Given this list of marker genes Trpv4, Ext2, Aqp2, Has2, Bpifa5, Adcy6, Bpifa1, Avp, Nfat5, Ctns, Mllt6, Sctr, Inpp5k, Aqp6, Atp6v1b1, Aqp7 (aquaporin 7), Scnn1b, Cftr, Wfs1, Scnn1a, Aqp1, Ext1, Scnn1g, Aqp3, Hyal2, Akr1b1, Aqp4, Akap11, Umod, here is a description of the gene set: species: Mus musculus Mouse Gene Set: GOBP_MULTICELLULAR_ORGANISMAL_LEVEL_WATER_HOMEOSTASIS A chemical homeostatic process involved in the maintenance of a steady state level of water within extracellular body fluids, such as blood, xylem or phloem, of a multicellular organism. This is distinct from maintenance of cellular homeostasis, which occurs within a cell.